Given this list of marker genes DUSP5, DUSP16, DUSP1, DUSP4, DUSP2, DUSP6, DUSP9, DUSP10, DUSP21, DUSP7, DUSP18, DUSP14, DUSP8, here is a description of the gene set: studied in species Homo sapiens Human Gene Set: GOMF_MAP_KINASE_TYROSINE_SERINE_THREONINE_PHOSPHATASE_ACTIVITY Catalysis of the reaction: MAP kinase serine/threonine/tyrosine phosphate + H2O = MAP kinase serine/threonine/tyrosine + phosphate.